The following is a description of a gene set: Human Gene Set: KEGG_MEDICUS_VARIANT_DUPLICATION_OR_MUTATION_ACTIVATED_FLT3_TO_JAK_STAT_SIGNALING_PATHWAY Pathway Definition from KEGG: FLT3* -> STAT5 => PIM1/2 Duplication or mutation-activated FLT3 to Jak-STAT signaling pathway. Pathway ID: N00054. Pathway type: Variant. Pathway class: nt06275 Acute myeloid leukemia. species: Homo sapiens, and this is the list of marker genes: STAT5A, PIM2, STAT5B, PIM1, FLT3